The following is a description of a gene set: studied in species Homo sapiens Recurrent intrapulmonary hemorrhage A recurrent hemorrhage occurring within the lung. Human Gene Set: HP_RECURRENT_INTRAPULMONARY_HEMORRHAGE, and this is the list of marker genes: CTLA4, PRTN3, PTPN22, WAS, WIPF1, HLA-DPA1, COL3A1, HLA-DPB1